The following is a description of a gene set: Angina pectoris studied in species Homo sapiens Human Gene Set: HP_ANGINA_PECTORIS Paroxysmal chest pain that occurs with exertion or stress and is related to myocardial ischemia., and this is the list of marker genes: APOA1, HLA-DPA1, ACTC1, APOB, LMNA, XYLT1, ELN, IDUA, ABCC6, JPH2, PCSK9, PTEN, PTPN22, CYP27A1, CTLA4, PMM2, LIPC, ABCG8, ZMPSTE24, APOE, PRTN3, TTR, TNNC1, ATP13A3, LCAT, HLA-DPB1, LDLR, ENPP1, PNPLA2, ABCA1, XYLT2, GLA, JAK2, TNNT2, ABCG5, LDLRAP1